Given this list of marker genes SESN1, SESN2, UBR2, GLUD2, GLUD1, UBR1, SESN3, here is a description of the gene set: species: Homo sapiens Binding to L-leucine, 2-amino-4-methylpentanoic acid. Human Gene Set: GOMF_L_LEUCINE_BINDING